Given this list of marker genes Ctnnbl1, Gm23925, Gm24411, Hck, Nfs1, Rbm39, Actr5, Gm14173, Gm14204, Rprd1b, Bcl2l1, Bpifa1, E2f1, Mmp24os1, Actl10 (NCBI Gene Id 70362), 4930405A21Rik, Bpifb5, Pdrg1, Arhgap40, Bpifb6, Rab5if, Dnmt3b, 4930519P11Rik, Gm14170, Bpifa6, Gm14277, Gm14197, Bpifa2, D630003M21Rik, Mcts2, Gm14286, Gm26003, Gm25129, Gdf5, Gm25187, Gm14279, Romo1, 6430550D23Rik, Gm14200, 2010009K17Rik, Tm9sf4, Rpl21-ps9, Zfp341, Defb36, Gm14168, Trp53inp2, Bpifa5, Gm14214, Bpi, Gm14276, Bpifb3 (BPI fold containing family B, member 3), Bpifb1, Sun5, Map1lc3a, Gm14239, Pofut1, Gm17416, Rpl5-ps2, 5730471H19Rik, Spag4, Uqcc1, Mtcl2, Xkr7, Gm25407, Gm14248, Mapre1, Gm14172, Efcab8 (NCBI Gene Id 329541), Gm14472, Tgif2, Vstm2l, Pxmp4, Tldc2, Cdk5rap1, Dusp15 (dual specificity phosphatase-like 15), Bpifb4, Gm14161, Nol4l, 1700003F12Rik, Gm14198, Mroh8, Defb25, Rbm12, Ggt7, Defb19, Ghrh, Raly, Gm14497, Rpn2, Tspyl3, Asxl1, Epb41l1, Dlgap4, Src, Gm14226, Dhx35, Gm14494, Nnat, Rem1, Cox4i2, Dynlrb1, Dnmt3bos, Lbp, H13, Gm23463, Scand1, Itch, Procr, Edem2, Fer1l4, Necab3, Tpx2, Mir5622, Gm22334, Ahcy, Eif6, Eif2s2, Gm14176, Snhg11, Snta1, Gm14231, Gm45609, Myh7b (NCBI Gene Id 674786), Defb21, Kif3b, Cnbd2, Ncoa6, Trpc4ap, Samhd1, Snhg17, Gm14238, Gss, Ttll9, Ppp1r16b, Slc32a1, 2500004C02Rik, Gm14227 (NCBI Gene Id 668931), Acss2, Adig, Mir7685, Bpifb9a (NCBI Gene Id 98944), Chmp4b, 1700060C20Rik, 2310005A03Rik, Platr27, Gm14199, Rbl1, Myl9, Bpifb2, Gssos2, Fam83d, Gm14215, Sla2, Ralgapb (Ral GTPase activating protein, beta subunit (non-catalytic)), Ergic3, Mir499, Norad, Gssos1, Mir3474, Dsn1, Gm14174, Mir695, Cep250, a, Cpne1, 4930404H24Rik, Tgm2, Fam83c, Gm14216, Gm14240, Dnmt3c, Blcap, Commd7, Defb45, Bpifa3, Cbfa2t2, Mmp24, Foxs1, Phf20, Mylk2, Aar2, Pigu, Id1, Manbal, Bpifb9b, Gm14162, Tti1, 4930518I15Rik, Gm14253, Ndrg3, Acss2os, 5430405H02Rik, Gm14163, Ccm2l, Gm14278, Gm14251, 1700030C14Rik, Plagl2, here is a description of the gene set: Mouse Gene Set: chr2H1 studied in species Mus musculus